The following is a description of a gene set: studied in species Homo sapiens Human Gene Set: REACTOME_NUCLEAR_ENVELOPE_BREAKDOWN Nuclear Envelope Breakdown, and this is the list of marker genes: VRK1, NUP205, RANBP2, LEMD3, VRK2, NEK6, AAAS, LMNB1, NUP155 (NCBI Gene Id 9631), TMPO, CDK1, PRKCB, POM121C, NUP35, CCNB1, LMNA, NUP54, BANF1, CTDNEP1, NUP153, NUP58, NUP93, NUP50 (nucleoporin 50), NUP43, PLK1, CCNB2 (cyclin B2), NEK9 (NIMA related kinase 9), NUP98, TPR, NUP107, NUP42, RAE1, NUP37, LPIN2, LPIN1, LPIN3, NUP214, EMD, SEH1L, NUP133, NUP85, NDC1, NUP88, NUP160, NUP188, SEC13, NEK7, NUP210, NUP62, PRKCA, LEMD2, CNEP1R1, POM121